Given this list of marker genes DCX, LARGE1, MTHFS (NCBI Gene Id 10588), ZIC1, RNU4ATAC, NDUFB11, CUX1, ASXL3 (NCBI Gene Id 80816), GFM2, COG5 (component of oligomeric golgi complex 5), VPS13A, NFIX, TMEM147, ADNP, TAF8, KMT2D, TUBB2B, TYROBP, AARS2, RAC1, FBXW11, KIDINS220, PPP2R5D, EIF2B5, ATP6AP2, YY1, SPRED2, KLHL15, PUS3, VPS51, COASY, BICD2, SPG11, MAPKAPK5, TUBB3, DTYMK, PDHA1, GAN (gigaxonin), GRIN1, NEK1, ESAM, MED25, YIPF5, CLTC, VRK1, KCNJ6, TAOK1, SNRPN, KIAA0586, PTPN23, MEF2C, ODC1, AHI1, PSAT1, GLUL, KCTD1, COG1, ALG2, SON, SMAD2, EML1, CSPP1, RAB3GAP1, EZH2, HS6ST2, KDM6A, SATB1, ASPM, RNU7-1 (NCBI Gene Id 100147744), GRN (NCBI Gene Id 2896), USP18, ALDH6A1, WARS2, ZEB2, GCDH, SMG9 (SMG9 nonsense mediated mRNA decay factor), TTC5, PGAP3, CCDC174, SLC35A2, IFT56, CLCN3, TNFRSF11A, NAA80, SRPK3, D2HGDH, LIPT2, EBF3, ZIC2, DOCK6, PIGA (phosphatidylinositol glycan anchor biosynthesis class A), KIAA0753, LONP1, here is a description of the gene set: Human Gene Set: HP_LATERAL_VENTRICLE_DILATATION species: Homo sapiens Lateral ventricle dilatation